Given this list of marker genes Anapc11, Anapc16, Anapc5, Ube2e1, Ube2d1, Cdc16, Ube2c, Cdk1, Ccnb1, Anapc2, Anapc1, Anapc7, Cdc26, Plk1, Anapc4, Anapc10, Ube2s, Cdc27, Cdc23, Anapc15, here is a description of the gene set: Phosphorylation of the APC/C Mouse Gene Set: REACTOME_PHOSPHORYLATION_OF_THE_APC_C species: Mus musculus